Given this list of marker genes NDUFS4, HMGCR, NDUFA4, COX6A2, SURF1, MIPEP, KCNJ18, AFG3L2, ISCU, SCN4A, MT-TN, MSTO1, SUCLG1, PNPLA2, ABHD5, GABRA3, CHCHD10, CACNA1S, STAC3, COQ8A, SDHA, KCNE3, here is a description of the gene set: Human Gene Set: HP_INCREASED_INTRAMYOCELLULAR_LIPID_DROPLETS An abnormal increase in intracellular lipid droplets In a muscle. The number and size of these drops can increase with somd disorders of lipid metabolism affecting muscle. See for histological images. studied in species Homo sapiens Increased intramyocellular lipid droplets